Given this list of marker genes SVIL, TGFB1I1, CTDSP1, FKBP4 (NCBI Gene Id 2288), UBE2I, KDM1A, PRKDC, LATS2, TCF4, XRCC5, CDK11B, NCOA4, CCND1, CMTM2, PATZ1, PAWR, UBE3A, HIP1, GSN, NCOA6, CDK6, FHL2, CARM1, ZNF318, PIAS3, NCOA2, PIAS4, SNURF, TMF1, BRCA1, NRIP1, XRCC6, KLK2, PA2G4, SRF, TGIF1, PELP1, PRDX1, HNRNPA1, APPL1, MED1, ZMIZ1, RPS6KA3, KDM4C, PTK2B, AKT1, AR, CASP8, PIAS1, CTNNB1, NKX3-1, CCND3, MAK, TMPRSS2, VAV3, RANBP9, KDM3A, UBA3, KLK3, CTDSP2, CDKN2A, here is a description of the gene set: Human Gene Set: PID_AR_PATHWAY studied in species Homo sapiens Coregulation of Androgen receptor activity from publication Schaefer CF, Anthony K, Krupa S, Buchoff J, Day M, Hannay T, Buetow KH (PMID 18832364)